Given this list of marker genes Abcc3, Rflna, Zfp354b, H2-T3, Trim15, Tnfrsf8, Robo2, Cd44, Kcnab1, Edn2, Loxl3, Adarb2, Lama4, Brinp3 (NCBI Gene Id 215378), Car14, Cnmd, Fxyd5, Mc4r, Pth2r, Mst1, Or10ac1, Tmem26, Ucp1, Pcdhga1, Pdzd7, Tmem45b, Ciita, Tcam1, Pak5, Megf10, Miox, Psmb11, Sox17, Chodl, Prss36, Erich6, Tekt2, Cnn1, Kcnj5, Tmem63c, Cimip2b, Mamdc2, Islr (immunoglobulin superfamily containing leucine-rich repeat), Mogat1, Cdkn2c, Fibin, Hoxb13, Cxcl1, Alox8, Chst3, Wnt8a, Tgm1, Meis1, Clec14a, Pde11a, Tgfb3, Cacnb3, Erich5, Kcnj2, Mst1r, Fgf10, Tmem125, Plcxd3, Islr2, Nckap5, Gucy1a1, Pamr1, Spink2, Rgs8, Mfsd2b (NCBI Gene Id 432628), Col4a4, Cryaa, Tnfrsf13c, Slfn5, Itih5, Gas2l2, Tppp3, Crabp2, Ypel4, Slc2a10, Fgl2, Foxs1, Adamts16, Ptgs1, Noto, Dkk1, Kcnk10, Hcar1, Prokr1, Or2b11, Rem2, Col7a1, Ptn, Phyhip, Kcnd2, Gnat1, Grm3, Col4a3, Nol3, Nrbp2, Lta, Vav1, Bicdl2, Adam33, Trim46, Col24a1, Klhl1, Gpr84, Esr2, Rhoj, Klhl5, Lyl1, Crygn, Opcml, Tmem181b-ps, Npy2r, Extl1, AI593442, Tlr5, Etv2, Mrgpre, Osbpl5, Caly, Snca, Pdyn, Scnn1a, Ptprr, here is a description of the gene set: from publication Mikkelsen TS, Hanna J, Zhang X, Ku M, Wernig M, Schorderet P, Bernstein BE, Jaenisch R, Lander ES, Meissner A (PMID 18509334) Somatic cells can be reprogrammed to a pluripotent state through the ectopic expression of defined transcription factors. Understanding the mechanism and kinetics of this transformation may shed light on the nature of developmental potency and suggest strategies with improved efficiency or safety. Here we report an integrative genomic analysis of reprogramming of mouse fibroblasts and B lymphocytes. Lineage-committed cells show a complex response to the ectopic expression involving induction of genes downstream of individual reprogramming factors. Fully reprogrammed cells show gene expression and epigenetic states that are highly similar to embryonic stem cells. In contrast, stable partially reprogrammed cell lines show reactivation of a distinctive subset of stem-cell-related genes, incomplete repression of lineage-specifying transcription factors, and DNA hypermethylation at pluripotency-related loci. These observations suggest that some cells may become trapped in partially reprogrammed states owing to incomplete repression of transcription factors, and that DNA de-methylation is an inefficient step in the transition to pluripotency. We demonstrate that RNA inhibition of transcription factors can facilitate reprogramming, and that treatment with DNA methyltransferase inhibitors can improve the overall efficiency of the reprogramming process. studied in species Mus musculus Mouse Gene Set: MIKKELSEN_IPS_ICP_WITH_H3K4ME3_AND_H327ME3 Genes with intermediate-CpG-density promoters (ICP) bearing the bivalent tri-methylation marks at H3K4 (H3K4me3) and H3K27 (H3K27me3) in MCV8.1 cells (induced pluripotent cells, iPS).